The following is a description of a gene set: Targets of MITF such as CEACAM1, GMPR and DIAPH1 contribute to cellular mobility and invasion by affecting cellular adhesion and regulating the actin cytoskeleton. MITF also regulates expression of genes involved in EMT such as SNAI2. MITF-dependent changes in invasiveness are of particular interest in the context of melanoma. Reactome Pathway: Regulation of MITF-M dependent genes involved in invasion species: Homo sapiens part of: MITF-M-dependent gene expression, and this is the list of marker genes: MITF, DIAPH1, CEACAM1, GMPR